The following is a description of a gene set: Human Gene Set: HP_MOTTLED_PIGMENTATION studied in species Homo sapiens Patchy and irregular skin pigmentation. Mottled pigmentation, and this is the list of marker genes: ZMPSTE24 (zinc metallopeptidase STE24), RECQL4, LTV1 (LTV1 ribosome biogenesis factor), KRT5, DUOX2, HPGD, LMNA, KRT14